Given this list of marker genes TTYH1, CLCN3, TTYH2, TTYH3, CLCN2, here is a description of the gene set: studied in species Homo sapiens Enables the transmembrane transfer of a chloride ion by a volume-sensitive channel. A volume-sensitive channel is a channel that responds to changes in the volume of a cell. Human Gene Set: GOMF_VOLUME_SENSITIVE_CHLORIDE_CHANNEL_ACTIVITY